The following is a description of a gene set: Pathway Definition from KEGG: (RSPO+LGR4/5/6)) -| (ZNRF3,RNF43) -| FZD studied in species Homo sapiens Human Gene Set: KEGG_MEDICUS_REFERENCE_WNT_SIGNALING_MODULATION_LGR_RSPO Wnt signaling modulation, LGR/RSPO. Pathway ID: N01440. Pathway type: Reference. Pathway class: nt06505 WNT signaling., and this is the list of marker genes: FZD8 (NCBI Gene Id 8325), RSPO3, RSPO2, ZNRF3, FZD7, RSPO4, FZD6, LGR4, FZD2, LGR6, FZD9, LGR5, RNF43, RSPO1, FZD10, FZD3, FZD1, FZD5, FZD4